The following is a description of a gene set: Pathway Definition from KEGG: PDGFR* -> PI3K -> PIP3 -> AKT -> MTOR Human Gene Set: KEGG_MEDICUS_VARIANT_AMPLIFIED_PDGFR_TO_PI3K_SIGNALING_PATHWAY studied in species Homo sapiens Amplified PDGFR to PI3K signaling pathway. Pathway ID: N00040. Pathway type: Variant. Pathway class: nt06273 Glioma., and this is the list of marker genes: PIK3CD, PIK3CB, AKT1, PIK3CA, PDGFRA, AKT2, AKT3, MTOR